Given this list of marker genes Cav1, Ppp3cc, Ppp3r2, Ppp3cb, Ppp3ca, Ppp3r1, here is a description of the gene set: Mouse Gene Set: GOBP_NEGATIVE_REGULATION_OF_CALCIUM_ION_IMPORT_ACROSS_PLASMA_MEMBRANE studied in species Mus musculus Any process that stops, prevents or reduces the frequency, rate or extent of calcium ion import across plasma membrane.